Given this list of marker genes Ddx1, Dhx57, Ddx6, Ighmbp2 (NCBI Gene Id 20589), Dhx15, Dhx40, Ddx20, Ddx17, Ddx18, Supv3l1, Ddx3x, Mov10, Tdrd9, Ddx41, Ddx24, Dhx32, Ddx39a, Dhx33, Ddx42, Eif4a1, D1Pas1, Helz2, Skic2, Brip1, Ddx49, Pif1, Ddx52, Ddx59, Ddx10, Mov10l1, Ddx55, Eif4a3l1, Ddx5, Eif4a3, Mtrex, Dhx34, Ddx43, Ddx11, Fancm, Ddx51, Dhx9, Ddx50, Ddx3y, Ddx19a, Ythdc2, Dhx58, Ifih1 (NCBI Gene Id 71586), Ddx39b, G3bp1, Ddx4, Eif4a2, Rigi, Ddx19b, Dhx8, Ddx31, Ddx54, Tdrd12, Dhx38, Ddx47, Eif4a3l2, Upf1, Dhx30, Ddx21, Ddx25, Ddx56, Ddx46, Dhx29, Ddx27, Snrnp200, Dhx36, Ddx28, Aqr, here is a description of the gene set: Mouse Gene Set: GOMF_ATP_DEPENDENT_ACTIVITY_ACTING_ON_RNA Catalysis of the reaction: ATP + H2O = ADP + phosphate; this reaction requires the presence of RNA, and it drives another reaction. species: Mus musculus